Given this list of marker genes PDGFRA, NF1, SDHD, CR2, CD19, NFKB2, IRF2BP2, SDHC, SDHA, TNFRSF13B, CD81, MS4A1, NFKB1, TNFSF12, TNFRSF13C, SDHB, KIT (KIT proto-oncogene, receptor tyrosine kinase), ICOS, here is a description of the gene set: studied in species Homo sapiens Gastrointestinal stroma tumor Human Gene Set: HP_GASTROINTESTINAL_STROMA_TUMOR